Given this list of marker genes Vstm5 (NCBI Gene Id 69137), Smox, Dtna, Csn1s2b, Znrf3, Aida, Cables2, Dffa, Ptpn14, Ankrd44, Tead1, Zfp937, Kbtbd2, Eeig1, Slc25a13 (solute carrier family 25 (mitochondrial carrier, adenine nucleotide translocator), member 13), Camk1d, Tgfbr1, Garem2, Atad1, Vstm2a, Ube3a, Lasp1, Pfkfb3, BC037156, Trp63, Smarcal1, Jag1, Amer1, Elovl5, Pard3b, Apaf1, Klhl42, Zfp800, Map4k3, Esyt3, Reep6, Tssk2, Zc3h6, Mex3c, Syt4, Macf1, Tamalin, Crebrf, Hormad1, Calcrl, Or12j5 (olfactory receptor family 12 subfamily J member 5), Stard10, Cdk8, Pou2f2, 9330159F19Rik, here is a description of the gene set: Mouse Gene Set: MIR_203_5P species: Mus musculus from publication Chen Y, Wang X (PMID 31504780) Genes predicted to be targets of miRBase v22 microRNA mmu_miR_203_5p in miRDB v6.0 with MirTarget v4 prediction scores > 80 (high confidence targets).